Given this list of marker genes Epb41l1, Stc1, Nrcam, Cd38, Qng1, Ankrd28, Itga4, Sulf1, Hnrnpa2b1, Abca6, Def8, Eif5b, Pudp, Trim33, Crisp2, 4930402K13Rik, Plppr4, Cenpx, Icosl, B020004C17Rik, Nucb2, Mtrex, Prune2, Arfip1, Slco5a1, Fut9, Slain2, Krt6a, Myt1l, Slc25a36, Gphn, Rps6ka6, Dipk2a, Prpf4b, Atrx, Zfp72, Galntl5, Clcn4, Lrp1b, Top1, here is a description of the gene set: Genes predicted to be targets of miRBase v22 microRNA mmu_miR_6359 in miRDB v6.0 with MirTarget v4 prediction scores > 80 (high confidence targets). studied in species Mus musculus from publication Chen Y, Wang X (PMID 31504780) Mouse Gene Set: MIR_6359